The following is a description of a gene set: Human Gene Set: HP_ATLANTOAXIAL_ABNORMALITY Atlantoaxial abnormality species: Homo sapiens An anomaly of the atlantoaxial joint, i.e., of the joint between the first (atlas) and second (axis) cervical vertebrae., and this is the list of marker genes: COL2A1 (NCBI Gene Id 444981), DDR2, RMRP, NFIX, CHST14, POLR3A, DSE, ARSL, TRPV4, GNPTAB, DYM, COMP, B3GALT6, FKBP14